Given this list of marker genes CYB5A, CYB5R3, GSTO2, SLC23A1, SLC23A2, GSTO1, SLC2A3, SLC2A1, here is a description of the gene set: species: Homo sapiens Vitamin C (ascorbate) is an antioxidant and a cofactor in reactions catalyzed by Cu+-dependent monooxygenases and Fe++-dependent dioxygenases. Many mammals can synthesize ascorbate de novo; humans and other primates cannot due to an evolutionarily recent mutation in the gene catalyzing the last step of the biosynthetic pathway. Reactions annotated here mediate the uptake of ascorbate and its fully oxidized form, dehydroascorbate (DHA) by cells, and the reduction of DHA and monodehydroascorbate to regenerate ascorbate (Linster and Van Schaftingen 2007). Reactome Pathway: Vitamin C (ascorbate) metabolism part of: Metabolism of water-soluble vitamins and cofactors